The following is a description of a gene set: Any process that modulates the rate, frequency or extent of cGMP-mediated signaling. studied in species Mus musculus Mouse Gene Set: GOBP_REGULATION_OF_CGMP_MEDIATED_SIGNALING, and this is the list of marker genes: Pde11a, Guca1a (NCBI Gene Id 14913), Pde10a (NCBI Gene Id 23984), Nppb, Rundc3a, Gucy2d, Npr2, Nherf4, Mtnr1b, Adora2b, Kdr, Thbs1, Pde2a, Nppa, Nppc, Npr1